The following is a description of a gene set: Binding to a leucine zipper domain, a protein secondary structure exhibiting a periodic repetition of leucine residues at every seventh position over a distance covering eight helical turns. Mouse Gene Set: GOMF_LEUCINE_ZIPPER_DOMAIN_BINDING studied in species Mus musculus, and this is the list of marker genes: Ddit3 (DNA-damage inducible transcript 3), Cdc5lrt1, Cdc5l, Cdc5lrt4, Pawr, Nrl, Cdc5lrt10, Crx, Scn2a, Dapk3, Atf4, Aatf, Atf2, Mrtfa, Cdc5lrt7 (NCBI Gene Id 668205), Jdp2, Cdc5lrt9, Cdc5lrt8, Pmf1, Cdc5lrt6, Cdc5lrt5